Given this list of marker genes ALG10B, KCNJ2, KCNQ1, SCN4B, CALM2, KCNE2, NAA10, CAV3, KCNJ5, ANK2, CALM1, TBX5, SNTA1, CALM3, SCN10A, AKAP9, HCN4, CACNA1C, KCNE1, SCN5A, TANGO2, KCNH2, NOS1AP, TRDN, RYR2, here is a description of the gene set: Human Gene Set: HP_TORSADE_DE_POINTES A type of ventricular tachycardia characterized by polymorphioc QRS complexes that change in amplitue and cycle length, and thus have the appearance of oscillating around the baseline in the EKG. Torsade de pointes studied in species Homo sapiens